Given this list of marker genes Slc25a23, Slc25a25, Slc35d1, Slc17a9, Lrrc8a, Slc35c1, Abcd2, Slc29a4, Slc35a3, Slc25a17, Slc35d2, Slc25a42, Hnrnpa3, Slc35d3, Slc28a3, Slc28a2, Slc35a5, Slc35a1, Slc25a31, Slc35b3, Slc25a36, Atp2a1, Sidt2, Slc25a51 (NCBI Gene Id 77670), Slc35e3, Slc35b4, Slc25a33, Slc29a2, Slc35a2, Slc35b2, Slc29a3, Slc22a2, Slc25a54, Slc29a1, Slc28a1, Slc35b1, Abcc4, Panx1, Slc25a53, Abcd1, Slc25a32, Slc46a2, Slc25a19, Slc28a2b, Slc25a26, Ank, Slc25a4, Slc22a1, Slc19a1, Sidt1, Slc25a16, Slc25a5, Slc25a41, Slc33a1, Slc25a24, Tmem241, Abcc5, Slc25a47, here is a description of the gene set: species: Mus musculus Mouse Gene Set: GOMF_NUCLEOBASE_CONTAINING_COMPOUND_TRANSMEMBRANE_TRANSPORTER_ACTIVITY Enables the transfer of nucleobases, nucleosides, nucleotides and nucleic acids from one side of a membrane to the other.